The following is a description of a gene set: species: Mus musculus from publication Mikkelsen TS, Ku M, Jaffe DB, Issac B, Lieberman E, Giannoukos G, Alvarez P, Brockman W, Kim TK, Koche RP, Lee W, Mendenhall E, O'Donovan A, Presser A, Russ C, Xie X, Meissner A, Wernig M, Jaenisch R, Nusbaum C, Lander ES, Bernstein BE (PMID 17603471) Genes with high-CpG-density promoters (HCP) without H3 methylation marks at K4 and K27 in embryonic stem cells (ES). We report the application of single-molecule-based sequencing technology for high-throughput profiling of histone modifications in mammalian cells. By obtaining over four billion bases of sequence from chromatin immunoprecipitated DNA, we generated genome-wide chromatin-state maps of mouse embryonic stem cells, neural progenitor cells and embryonic fibroblasts. We find that lysine 4 and lysine 27 trimethylation effectively discriminates genes that are expressed, poised for expression, or stably repressed, and therefore reflect cell state and lineage potential. Lysine 36 trimethylation marks primary coding and non-coding transcripts, facilitating gene annotation. Trimethylation of lysine 9 and lysine 20 is detected at satellite, telomeric and active long-terminal repeats, and can spread into proximal unique sequences. Lysine 4 and lysine 9 trimethylation marks imprinting control regions. Finally, we show that chromatin state can be read in an allele-specific manner by using single nucleotide polymorphisms. This study provides a framework for the application of comprehensive chromatin profiling towards characterization of diverse mammalian cell populations. Mouse Gene Set: MIKKELSEN_ES_HCP_WITH_H3_UNMETHYLATED, and this is the list of marker genes: Slitrk2, Ahrr, Spire1, Cryga, 1700018B24Rik, Rasgrp3, Il20rb, Cnga4, Olfm3, Camk2a, Asz1 (NCBI Gene Id 74068), Fscn2 (NCBI Gene Id 238021), Lypd2, 4921504E06Rik, Psd3, Edar, Rcvrn, Pdha2, Slc26a5, Dpep3, Sstr2, Pcdhb18, Dmrtc1a, Tbx22, Zfp959, Nscme3l, 1700020N01Rik, Dusp13b, Cacng2, Tssk2 (testis-specific serine kinase 2), Slc2a9, Trpm1, Ccdc110, Mfap2, Fxyd2, Trmt2b, Palmd, Ces5a, Tnfrsf9 (tumor necrosis factor receptor superfamily, member 9), Rho, Tex101, Trpc3, Krt26, Pcdhb10, Krt27, Pcdhb4, Sst, Piwil1, Zdhhc25, Mgat4d, Sh3d19, Syp, Plce1, Tmem174, Tex11, Jph2, Dnajb8, Ly6k, Tex13b, Fgf6, Bahcc1, Zfp943, Riiad1, Pcdha8, Brdt, Nos1, Golga7b, Rbm28, Rph3a, Adam1a, Gigyf1, Abcc9